The following is a description of a gene set: species: Homo sapiens The developmental process in which an anatomical structure is destroyed as a part of its normal progression. Human Gene Set: GOBP_ANATOMICAL_STRUCTURE_REGRESSION, and this is the list of marker genes: LEF1, SMAD5, FLT1, DRD2, OPN4, OPN5, SLC17A6, CD248, GLI1, SLC6A3, LRP5 (LDL receptor related protein 5), AMH, SPI1, BMPR1A, AMHR2, TH